The following is a description of a gene set: studied in species Homo sapiens Human Gene Set: GOBP_EMBRYONIC_CRANIAL_SKELETON_MORPHOGENESIS The process in which the anatomical structures of the cranial skeleton are generated and organized during the embryonic phase., and this is the list of marker genes: TBX15, PAX5, LHX1, RUNX2, TULP3, NODAL, SIX4, RDH10, GRHL2, EIF4A3, SMAD2, TGFBR1, WDR19, MED12, SLC39A3, TGFBR2, TFAP2A, HOXA1, IRX5 (NCBI Gene Id 10265), PDGFRA, PRRX1, TBX1, NDST1, CHST11, NIPBL (NIPBL cohesin loading factor), MTHFD1L, MMP16, DLX2, MTHFD1, SLC39A1, IFT140, SMAD3, TWIST1, FOXC2, SIX2, HOXA2, BMP4, WNT9B, FGFR2 (NCBI Gene Id 2263), GLI3, SIX1, FGF8 (NCBI Gene Id 2253), MMP14